Given this list of marker genes CDK2AP2, CCNB2, DNAH6, PACS2, ISY1, MPST, SCARNA13, SEC22B, KLC1, AARSD1, ANKRD55, RPLP2, SHCBP1L, BID, FUT2, UQCC6, LRCH2, MRPL23, SLAMF9, VRK1, FMC1, GTF2H3, CCDC146, TIMD4, FERMT2, NDUFS2, TMEM242, TRMT112, LURAP1L, MRPL57, DACT1, CISD1, MPO, MRPL32, CALML3, ATF7, DAB2IP, LYRM4, BANP, KCNQ3, PRPSAP2, TMUB1, METRN, PPBP, PRCP, UQCR10, SLC22A18, KIAA0825, RNF167, AK2 (adenylate kinase 2), KGD4, NME3, SPC24, HS3ST3A1, ARPC5L, UCP3, C11orf58, OSTC, SLC35F2, ACRBP (NCBI Gene Id 84519), BAX, LSP1, MARVELD3, SNRNP27, RARRES2, NUBPL, UTP14A, DTD2, LAMTOR4, SLC13A1, TRAPPC6B, POMP, PDCD2, MRPS14, UPK1A, LY6E, STOML2, HLX, ALKBH3, TEX56P, RAB39A, TMEM74, MRPL45, VEZT, LAMA2, TBRG1, CUTA (cutA divalent cation tolerance homolog), ELOVL5, DMAP1, CHURC1, PCDH18, PHLDA3, LGALS3BP, ACTL6B, MIOX, RSU1 (Ras suppressor protein 1), FAP, PCDH8 (protocadherin 8), GAR1, MRPL24, MORN2, PCDH10, HIGD1C, UNC119, CAV2, GINS4, MIA2 (MIA SH3 domain ER export factor 2), BANF1, SRD5A1, UNC80, HIGD2A, AIFM3, EMC7, SCNM1, STK33, CRYBG2, DHX34, TBXT, SMDT1, MRPL19, MRPL21, NUP43, MCTP1, NPM3, RXRA, GADL1, PRDX3, PSMG1, C11orf86, HAUS1, PISD, ISCA2 (NCBI Gene Id 122961), NFKBIB, NOS1AP, SSTR3, BTN1A1, RPP14, PTPRCAP, SMOX, MRPS16, FARS2, PHOSPHO2, NDUFS3, LHPP, PSMG4, PITPNM3, MIX23, HOGA1, MPLKIP, LYPD4, PYCARD, TSPAN1, CIAO2B, LCN12, LIN28B, SIRT7, PCDHAC1, GPRC5D, TIMM8B, RPL36, ALDH2, C19orf53, PSMB1, IL13RA1, KRT222, SETD5, CSTPP1, MGST1, ARMC3, PRRT4, SALL4, LHFPL2 (NCBI Gene Id 285713), POLM, OSTF1, OIT3, POLR1H, LIME1, IL15RA (NCBI Gene Id 3601), EMCN, MOGAT1, NDUFA7, MYH1, PSMB10, SNRPF, MCU, MPND, KRTAP19-1, EMG1, CEMIP, AIG1, TIMM10B, SEC13, GPD1, GCA, DCTPP1, TMEM39A, ISCU, HEBP1, POLR2E, here is a description of the gene set: Human Gene Set: GSE39820_TGFBETA1_VS_TGFBETA3_IN_IL6_TREATED_CD4_TCELL_DN Genes down-regulated in comparison of CD4 T cells treated with TGFB1 versus those treated with TGFB3 and IL6. species: Homo sapiens TGF-beta3 produced by developing Th17 cells induces highly pathogenic T cells that are functionally and molecularly distinct from TGF-beta1-induced Th17 cells. The microarray data represent a distinct molecular signature for pathogenic versus non-pathogenic Th17 cells. from publication Lee Y, Awasthi A, Yosef N, Quintana FJ, Xiao S, Peters A, Wu C, Kleinewietfeld M, Kunder S, Hafler DA, Sobel RA, Regev A, Kuchroo VK (PMID 22961052)